The following is a description of a gene set: studied in species Homo sapiens Human Gene Set: GOMF_DEATH_RECEPTOR_BINDING Binding to a member of the death receptor (DR) family. The DR family falls within the tumor necrosis factor receptor superfamily and is characterized by a cytoplasmic region of ~80 residues termed the death domain (DD)., and this is the list of marker genes: EDA, NTF4, NGF, FADD, MYD88, NTF3, CASP3, MADD, NOL3, BDNF, CASP8AP2 (caspase 8 associated protein 2), FEM1B, RIPK1, BID, TMBIM1, PIDD1, CASP8, CFLAR, DAB2IP, FASLG, BEX3